Given this list of marker genes FZD1, SCARB1, AGK, CCDC39, G3BP1, SCUBE3, PAPLN, EYA4, ST8SIA4, AHCYL2, PPP2R2B, IL5RA, PTBP2, TTK, RAB11FIP2 (NCBI Gene Id 22841), MUC15, MFAP5, ELAVL1, KBTBD6, CDC23, CNST, ZNF197, PROM2 (NCBI Gene Id 200480), DUSP14, VSTM2A, SEC62, SMARCE1, ASB4, HEATR5A, ZNF569, CHL1, ZNF655, XK, FIGN, FAM81A, GPATCH2, DBX2, KNG1, PPARGC1B, ARHGAP12, ZDBF2, ZFP14, PPDPFL, KAT2B, SH3D19, LACC1, CPEB2, OMD, DROSHA, CTSC, ELAVL2, NSD2, PTBP3, BICD2, TAS2R13, ZNF143, ZZZ3, SLC35F1, UNC45B, SPHKAP, BPNT1, XRCC2, FOXJ3, EPHA4, AMTN, RAPH1, AASS, FOXO1, CTNND2, PPP1R21, RHOBTB3, API5, here is a description of the gene set: Genes predicted to be targets of miRBase v22 microRNA hsa-miR-6731-3p in miRDB v6.0 with MirTarget v4 prediction scores > 80 (high confidence targets). species: Homo sapiens from publication Chen Y, Wang X (PMID 31504780) Human Gene Set: MIR6731_3P